Given this list of marker genes Csnk1e, Spon1, Abca2, App, Clu, Casp3, Chrna7, Ifngr1 (NCBI Gene Id 15979), Rela, Efna3, Abcg1, Lrrtm3, Efna1, Picalm (phosphatidylinositol binding clathrin assembly protein), Lyn, Ranbp9, Ager, Rock2, Slc2a13, Tnf, Epha4, Gsap, Gsk3a, Apoe, Ifng, Sp1, here is a description of the gene set: Mouse Gene Set: GOBP_POSITIVE_REGULATION_OF_AMYLOID_PRECURSOR_PROTEIN_CATABOLIC_PROCESS species: Mus musculus Any process that activates or increases the frequency, rate or extent of amyloid precursor protein catabolic process.